Given this list of marker genes NOP58, NOPCHAP1, RPL22, GHR, KIF2A, DICER1, TCEAL9, PACRGL (parkin coregulated like), COPS4, NIFK, SRSF3, MTMR10, SLC7A6, GCSH, SH3D19, PLA2G6, RCL1, GCLM, FCF1, LAPTM4B, GANAB, UBE2T, RYK, ARCN1, ROCK2, CTBP2, TGS1, WDR55, ACADM, MRPL17, RRN3, SMAD1, PEX7, ITGB1, FASTKD5, LSM2, RPP14, RSL1D1, UPP1, EIF4EBP1, MTERF3, FKBP9, ZFX, YES1, UTP20, PCF11, GNB1, LSG1, PAFAH2, RIDA, YWHAH, ZMYM4, ELP2, ELOVL6, RNF145, SLC38A2, SNRPC, PPA1, MRPS31, GAB1, TRIP6, NDUFAF4, GCAT, SAPCD1, ESF1, TXNDC9, CPXM1, SMARCAD1 (SWI/SNF-related, matrix-associated actin-dependent regulator of chromatin, subfamily a, containing DEAD/H box 1), PSMD11, PHTF2, NUP35, RASA1, ITGA6, RCN1, ZZZ3, ZCCHC10, ALDH7A1, ZNF644, MAP4K3, LIG3, JAGN1, DNAJB6 (NCBI Gene Id 9186), GLO1, TXNRD1, PRPF6, GRWD1, TOM1L1, ABCB1, BLZF1, CWC22, ZC3H14, MPDU1, YAP1, COPS7A, KANK3, STXBP3, RPUSD4, DCTPP1, MDFI, CHD1, ERCC5, SEC23IP, RIMOC1, FBXO8, ZNF281, RAB18, SMAD2, CCND1 (cyclin D1), UTP4, PPP2R1B, PIGX, PDCD2, STAM, RARS2, TBRG4, F2R, GFER, FHL1, EIF4G2, PPP1R2, UMPS, DTYMK, URI1, CTTN, PPIC, CDKN1A, WDR43, PLS3, FKBP11, GNL2, TEAD2, CENPC, BACH1, RAD23B, ZNF213, RNF4, TJP1, SOCS2, GAS2, TBRG1, ACAT2, SEC23A, IARS1, PSMD12, GARS1, EPRS1, XRCC5, BPNT2 (3'(2'), 5'-bisphosphate nucleotidase 2), ARIH1, MRPS2, LIMA1, KRAS, PRPSAP1, MRPS10, ANKRD17, DPH5 (diphthamide biosynthesis 5), RSRC2, SLC4A7, FBXO38 (NCBI Gene Id 81545), RNF138, TARS2, RNFT1 (ring finger protein, transmembrane 1), CRTAP, PKD2, SRSF6, TBC1D15, XPO1, SNX12, USP9X, ZNF639, ZMAT3, TGIF2, PTPN2, LAS1L, MPHOSPH10, IARS2, KCNAB3, XPOT, ADAM9, TMEM183A, LAPTM4A, LRRC58, CDK2AP1, MRPL45, MDFIC, EIF3J, COPRS, SUCLG2, USP10, MED23, MARCHF7, MRPL34, ZNF486, BYSL, YWHAB, RABGGTB, here is a description of the gene set: species: Mus musculus Genes enriched in embryonic, neural and hematopoietic stem cells. Human Gene Set: RAMALHO_STEMNESS_UP from publication Ramalho-Santos M, Yoon S, Matsuzaki Y, Mulligan RC, Melton DA (PMID 12228720) The transcriptional profiles of mouse embryonic, neural, and hematopoietic stem cells were compared to define a genetic program for stem cells. A total of genes are enriched in all three types of stem cells, and several of these genes are clustered in the genome. When compared to differentiated cell types, stem cells express a significantly higher number of genes (represented by expressed sequence tags) whose functions are unknown. Embryonic and neural stem cells have many similarities at the transcriptional level. These results provide a foundation for a more detailed understanding of stem cell biology.